The following is a description of a gene set: Genes predicted to be targets of miRBase v22 microRNA mmu_miR_6913_3p in miRDB v6.0 with MirTarget v4 prediction scores > 80 (high confidence targets). from publication Chen Y, Wang X (PMID 31504780) studied in species Mus musculus Mouse Gene Set: MIR_6913_3P, and this is the list of marker genes: Zfp992, Wbp11, Zfp987, Ube2j1, Hdac9, Zeb1, Rgs5, Zfp493, Ccdc169, Arhgap24, Ccnjl, Zfp345, Dpm1, Myocd, Cdc14a, Slc18a2, Igsf3, Nt5dc1, Rtkn2, Shank2, Zfp445, Ash1l, Zfp459, Prelid3a, Ddx19a, Ptpro, Haus2, Gid8, Sost, Mapre2, Thap1, Mgat3, Zfp629, Slc5a9, Fstl5, Podxl, E2f6, Gmfb, Mri1, Zfp946 (zinc finger protein 946), Nxt1, Usp38, Zfp985, Jade1, Cab39, Usp1, Slc23a2 (NCBI Gene Id 99086), Chrdl1, Usp27x, Ccr3, Gas2, Gapvd1, Ttll4, Pcdh11x, Cdk12, Hspd1, Me3, Snip1, Fam136a, Camta1, Zfp770, Zfp991, Steep1, Prorsd1, Pgr15l, Oser1, Myt1, Ptma, Dner, Lpgat1, Sinhcaf